The following is a description of a gene set: species: Homo sapiens The creation of a phagolysosome from a phagosome and a lysosome. Human Gene Set: GOBP_PHAGOSOME_LYSOSOME_FUSION, and this is the list of marker genes: RAB7A, RAB39A, RAB7B, RAB20, VPS33B, VIPAS39, RAB34, TMEM175, CLN3 (CLN3 lysosomal/endosomal transmembrane protein, battenin), SPG11, SYT7, PIKFYVE, PLA2G5, ARL8B